Given this list of marker genes ADGRG3, ATP11A, IQGAP2, IGLV3-19, FCAR, LYN, SCAMP1, LY96, GHDC, BST1, PLCG2, C8A, YES1 (YES proto-oncogene 1, Src family tyrosine kinase), PGM2, CLEC4C, PRKCQ, OLR1, POLR3A, DEFB105A, WAS, PRKCSH, FYN, MUC17, TMT1A, PSMA2, MUC1 (NCBI Gene Id 4582), MUC4, TXK, PDZD11, ATP6V0D1, CCL22, CMTM6, GMFG, GLIPR1, UBA7, CSNK2B, RNF216, DEFB127, RAP1A, ATP6AP2 (ATPase H+ transporting accessory protein 2), HLA-C, IGKV2D-40, LGALS3, WIPF2, ABI2, USP14, DUSP6, TUBB4B, IGHV3-30, NFATC1, MYO1C (myosin IC), FCN3, UBB, TTR, MUC3A, BCL2, ATP6V0A1, ELMO2, CTSB, S100A9, NIT2, ATG7, AGPAT2, CTSG, NOD1, TRIM32, CFP, SNAP23, LY86, CD59, PLCG1, SFTPD, CD247, IMPDH2, ITPR2, CTNNB1, PRKDC, PGLYRP1, C9, POLR3B, RHOG, IGKV3D-20, LGMN, FGL2, PSMD11, IGKV1-39, S100A8, SLC2A5, DEFB130B, LRRC14, NFASC, STOM (stomatin), MAP3K8, NKIRAS1, HTN1, PADI2, RNASE6, PKP1, DBNL, HEBP2, XRCC5, CNN2, RNASET2, ADGRE5, YPEL5, ARG1, HVCN1, LEAP2, TICAM2, IGHV3-23, MS4A2, MME, AAMP, UBR4, AMPD3, CREB1, BCL2L1, GSDME, DNM3, CAPZA1, DDX3X, CALM1, LYZ, DGAT1, PTPN11, ANPEP, NOS1, PDAP1, C1QA, ABI1, CD58, SARM1, NBEAL2, JUP, HEXB, ARHGAP9, GLB1, RAB5B, IGHV1-2, CREBBP, PAK2, DEFB126, TMEM179B, PRDX6, ARPC3 (NCBI Gene Id 10094), DEFB1, CYLD, ARPC1A, SIKE1, DEFB132, PTPRN2, PSMD6, TLR4, RBSN, ELANE, STING1, DUSP3, PSMA6, MUC5B, IGKV1-12, NOD2, OSCAR, TLR3, CCT2, SLC27A2, RASGRP1, DTX4, CD300LB, CAT, TCIRG1, GSDMD, PSMC6, PYCARD, DEGS1, PI3, HK3, MALT1, CEP290, CTSS, HMOX2, HGSNAT, IFNA10, PGM1, C7, CD53, ENPP4, IGKV1D-33, ITPR3 (NCBI Gene Id 3710), ATAD3B, NDUFC2, CXCL1, TRPM2, C1S, GUSB, IGHE, GM2A, PSMB2, C3, MYO10, PRDX4, PTAFR, EPPIN, LPO, PA2G4, ALDH3B1, UBE2D1, MASP2, CKAP4, CFHR4, ADAM8, GZMM, ATP6V0E2, PLD3, RAB4B, QPCT, IGLV1-44, NLRX1, NFKBIA, SPTAN1, RETN, PPIA, NLRP1, LIMK1, ARL8A, DEFB4A, TNIP2, RAF1 (NCBI Gene Id 5894), DIAPH1, TMBIM1, ICAM3, TLR1, PRCP, IGLV2-14, CYB5R3, PDXK, CDK13, SUGT1, MMP25, NCKIPSD, SLC15A4, TLR7, NOS3, SERPINB3, CAPZA2, FUCA1, FTH1, S100A12 (NCBI Gene Id 6283), PSMA4, MYD88, LAMTOR1, MLEC, NHLRC3, IFNA2, EEF2, ANXA2, ACTB, DEFB125, POLR3GL, IGHG1, ATG12, ROCK1, PGRMC1, IGLV3-1, CASP4, FGG, IGHG2, PPP3R1, DEFB110, ALAD, A1BG, MAPK7, SFTPA1, FGA, SYNGR1, SIGLEC15, SRP14, CPN1, TREM2, TAB1, RAB3A, MNDA, PPBP, CD19, DSC1, GAB2, CPPED1, TLR8, PTX3, CASP8, CD180, MGST1, IGKV2-28 (immunoglobulin kappa variable 2-28), NCR2, PGLYRP4, IFNA6, BTRC, SIRPA, HSP90AA1, SEMG1, DNM1, MUC5AC, GLA, DEFB108B, SLC2A3, IGKV2D-28, DNAJC3, HP, CD68, CFI, IFI16, CTSA, ATP6V1B1, MMP9, POLR2F, MAP2K7, PNP (NCBI Gene Id 4860), TMEM63A, IGKV2-30, DEFB104B, ARHGAP45, MYO9B, KRAS, MYH9, CXCR1, CRACR2A, PTPN4, IRF3, IGKV1D-12, ECSIT, MAP3K7, DEFA3, CRCP, RHOF, DEFB130A, CTSH, AGA (aspartylglucosaminidase), ATP6V1C1, PSMD7, SRC, RNASE8, SKP1, MUC15, CANT1, N4BP1, DEFB109B, ACTR10, IGKV1-5, NRAS, ORM1, IGHV4-34, EPPIN-WFDC6, IGLV2-23, CHUK, RPS6KA3, MUC7, ITCH, CD177, CD93, MEF2A, FCGR3B, ARPC2, SLPI, FCER1A, DERA (NCBI Gene Id 51071), IGF2R, C2, EEA1, IGLV6-57, TXNIP, GALNS, IFIH1, MEF2C, S100A1, DNAJC5, ATOX1, CD46, MAPK12, PPP2R1A, CFHR5, LBP, CRISP3, SERPING1, PLD4, BIRC2, MGAM (maltase-glucoamylase), PRSS3, C5AR1, REG3A, PSMB4, RPS27A, LAMTOR2, MAPKAPK2, CPB2, UBA3, DEFB104A, DEFB121, COMMD3, CTSV, SAA1, IGKV5-2, B4GALT1, SDCBP, CASP10, FCN2, TLR6, ATP11B, TAX1BP1, MAP3K1, NF2, UNC93B1, PPP2R5D, ABL1, CCT8, ATP6V1E2, MS4A3, IFNA14, CHIT1, IGHV3-7, C6orf120, PELI1, RNASE3, MOSPD2, DEFB4B, P2RX7, IGKV2D-30, ATF2, PPP2CB, DEFB103B, CTSL, SOS1, ARSA, POLR3K, MAVS, HSPA1A, MUC21, VAPA, DEFB115, LILRB3, CXCR2, PSMD8, FPR2, POLR2L, CASP9, COLEC10 (collectin subfamily member 10), POLR3C, DOCK2, IFNB1 (NCBI Gene Id 3456), PIK3R2, IGLV3-25 (NCBI Gene Id 28793), DDX41, ASAH1, SHC1, PSMD13, ATP6V0D2, OTUD5, NFATC2, MAPK13, IGHV1-46, NME2, IDH1, DEFB131A, CUL1, TNFRSF1B, RAB7A, TRAF6, CDA, C4BPB, HSP90AB1, FABP5, IGKV3-20, NPC2, CLEC10A, IFNA21, ALDOC, IL1B, KRT1, SIGIRR, SIGLEC9, IRF7, SURF4, PTPRC, CST3, MAPK8, MIF, REG3G, HPSE, IGHV3-13, VNN1, CYFIP2, PLAUR, PIK3CB, ORMDL3, GSTP1, PLD1, ATP6V1E1, DEFB114, CD3G, UBE2D3, STK10, DEFA5, UNC13D, HSPA6, IGLV7-43, PSMA7, ACTG1, AGER, MAPK11, DEFB136, VRK3, GGH, TIRAP, RNASE2, DDOST, ITGB2 (NCBI Gene Id 3689), IGHV2-70, SLC44A2, RAB18, PGAM1, RIPK1, PSMC3, TRIM21, TNFAIP3, IFNA8, CD81, RAB10, IKBKG, ADAM10, POLR2E, MYO5A, TMEM30A, DSP, DEFB103A, SLC11A1, VCL, S100A7, VAV1, RIPK3, DYNC1H1, HLA-E, UBC, ADA2, CAND1, POLR2H, GRB2, PPP2CA, DEFB119, WIPF1 (NCBI Gene Id 7456), SIGLEC5, RPS6KA2, RELB, RAB37, SERPINB12, CPNE1, STBD1, CYFIP1, DYNC1LI1, PLPP5, CLEC6A, DEFB113, PTGES2, DYNLT1, KPNB1, TLR2, KIR2DS1, DOCK1, IRAK4, OPTN, PLA2G2A, APRT, SEM1, RAP2B, POLR1C, MBL2, FTL, CD14, S100A7A, GRAP2, ISG15, LAMP1, ARPC1B, IGKV1-17, ATP6V1G1, PKM, BPIFB6, SNAP29, TICAM1, DEFB112, TKFC, IGLV1-40, DEFB107A (NCBI Gene Id 245910), DEFA6, TAB2, CLEC4A, TRIM4, PRG2, VAMP8, DEFB129, WIPF3, ITGAM, PSMB7, TP53, TOM1, DNM2, MAP2K3 (NCBI Gene Id 92079), DEFB135, CR2, TLR5, ACLY, PGLYRP2, PLAU, CD44, MUCL1, C4A, HRNR, IGHV4-39, KIR2DS2, LRRC7, ITGAL, CRP, KLRC2, IGHV3-53 (immunoglobulin heavy variable 3-53), NCF1, NLRC3, DYNLL1, LRRFIP1, VAV2, IGHV3-48, NLRP3, MRE11, ART1, KLRD1, HBB, DUSP7, ATP6V0B, COTL1, DNAJC13, IKBKE, PRKACA, PTPRB, NLRC4, RAP2C, QSOX1, MAPK1, ATP6V1B2, MYH2, EP300, PSEN1, PSTPIP1, MASP1, ILF2, PSMD12, BPIFB1, TIFA, FCN1, C4BPA, PPP3CA, IFNA13, MAP2K6, IGHV3-33, AHSG, PLEKHO2, DOK3, C4B_2, RIGI, RAB44 (RAB44, member RAS oncogene family), IRF5, RAB14, PYGL, CD55, DHX9, GNS, XRCC6, MUC13, BPIFB2, DEFB107B, MAPK10, PPP2R1B, CFHR2, CYBA, RASGRP4 (NCBI Gene Id 115727), CHI3L1, RAC1, VAV3, ATP6V0E1, NLRC5, CAP1, CTSZ, F2, TAB3, HMGB1, ATP6V1A, CD4, FADD, MVP, IRAK3, TYROBP, ITK, LILRB2, CEACAM3, IFNA5, SERPINB10, EEF1A1, PSMB5, SVIP, CTSK, NCF4, C5AR2, PELI3, APEH, CAB39, MAN2B1, RAB27A, AHCYL1, CFHR1, TMC6, RAB3D, ITLN1, POLR3E, VPS35L, PSMC2, NLRP4, TBK1, RNF135, IGHV3-11, PSMD3, MAP2K4, STAT6, AZU1, C5 (NCBI Gene Id 727), CASP1, RASGRP2, IGLV1-51, C8B, CREG1, IFNA4, LCK (NCBI Gene Id 95387), IFNA7, MAPK14, SIGLEC14, IMPDH1, TRAF3, IST1, TREX1, BST2, RAB24, ATP6V1H, PSMC1, DEFB106A, ATP6V0C, HTN3, HSPA1B, PLPP4, ITGAV, IGKV1D-16, CTSC, POLR3F, NKIRAS2, PIGR, S100A11, GYG1, IGKV1D-39, ACAA1, PIK3C3, RAC2, BPIFB4, BPI, CYSTM1, PSMA1, ARSB, C1QC, CTSD, BCL10, C1R, MUC16, PSMB6, TRAF2, DCD, PRKACG, BTK, PCBP2, C1QB, KIR2DS4, RHOA, USP18, ACTR2, C4B, TXN, POLR2K (NCBI Gene Id 5440), ITGAX, EPX, CALML5, PECAM1, DEFB116, TOLLIP, IGKV3-11, ARPC5, DNASE1L1, RAP1B, BRK1 (NCBI Gene Id 55845), ATP8A1 (ATPase phospholipid transporting 8A1), POLR3G, PTK2, HUWE1, WASF3, SFTPA2, CPN2, POLR3H, NCSTN (nicastrin), ADRM1 (ADRM1 26S proteasome ubiquitin receptor), KLRK1, BAIAP2, PTPRJ, ATF1, PYGB, IGHV4-59, NCF2, PLA2G6, CFL1, CCR2 (C-C motif chemokine receptor 2), IGLV3-27, PSAP, ADGRE3, NFKBIB, ATP8B4, NOS2, TUBB, ATP6V1F, CD33, PSMA5, CRISPLD2, UBE2K, KIR2DS5, FOLR3, CGAS, TSPAN14, IFNA1, MAPK9, ATP6V1G2, CHGA, ELK1, PDPK1, HSPA8, DEFB124, PSMB1, DSG1, CCL17 (NCBI Gene Id 6361), UBA52, UBE2N, CPNE3, ICAM2, PPP3CB, PGLYRP3 (peptidoglycan recognition protein 3), ATP6V0A4, RNF125, ATP6V1C2, CFH, IGHV1-69, STK11IP, FCGR3A, ITPR1, SIRPB1, ACTR1B, LTF, KCNAB2, PRG3, PSMB3, TLR9, CR1, FLG2, TOMM70, PSMC5, POLR3D, DEFA1B, TBC1D10C, WASL, GAA, DEFB105B, FCER1G, DSN1, PAK3, WASF2, CD47, TRIM25, IGKV4-1, ERP44, CARD11, RPS6KA5, PIK3CA, MUC6, C8G, GPR84, ANO6, IGKV1-16, CAMP, MMP8, LAMP2, VTN, MAP2K1, IFNA16, FUCA2, ENSG00000284217 (NCBI Gene Id 128966554), LAT, CLEC12A, DEFB118, ATP7A, IRAK2, HCK, IGHV2-5 (NCBI Gene Id 28457), FRK, RAB31, BPIFA2, PFKL, CEACAM8, CYBB, BIRC3, APOB, CD300A, MEFV, FGR, ATG5, GPI, S100P, TXNDC5, PPIE, C3AR1, TANK (NCBI Gene Id 10010), MAP3K14, BPIFA1, ATP6V0A2, RELA, DEFB106B, MANBA, GCA, DEFA4, TEC, CRK, PAFAH1B2, VAT1 (NCBI Gene Id 10493), HERC5, ALDOA, B2M, TRIM56, CEACAM6, PELI2, PLAC8, IGKV1-33, FCGR2A, TARM1, CCR6, DEFB133 (defensin beta 133 (pseudogene)), TASL, LPCAT1, SNAP25, COMMD9, GNLY, CDC34, OSTF1, ACP3, CD36, CD63, ALOX5, SERPINB6, ALPK1, IGLC2, MUC12, WASF1, RPS6KA1, HRAS, CARD9, RAB6A, ELMO1, SLCO4C1, ACTR3, LAT2, IGLV3-21, LRG1, IGHG4, CSTB (NCBI Gene Id 1476), VCP, IRAG2, SERPINA1, SOCS1, GRN, ARMC8, HSP90B1, NCKAP1, NAPRT, CLEC5A, P2RX1, AOC1, SERPINA3, SYK, TLR10, IGLV1-47, AP1M1, OLFM4, NCK1, PSMD14, RIPK2, FBXW11, FCGR1A, PRSS2, TNFAIP6, ORM2, S100B, PRTN3, MAPK3, MCEMP1, FOS, IFNA17 (NCBI Gene Id 3451), CLEC7A, DEFB134, FRMPD3, PIK3R1, PSMC4, PRKACB, PIN1, PIK3R4, RAB9B, PSMD2, ABCA13, LAIR1, IKBIP, MUC20, LILRA3, APP, DHX36, POLR1D, MAPKAPK3, UBE2M, CEACAM1 (CEA cell adhesion molecule 1), FAF2, LCP2 (lymphocyte cytosolic protein 2), PSMD1, TCN1, UBE2D2, BRI3, PRKCD, DHX58, PLD2 (NCBI Gene Id 5338), CASP2, UBE2V1, IKBKB, MAGT1, FGB, TRAPPC1, FPR1, ATP6V1D, LTA4H, HLA-B, ATP6V1G3, COPB1, BIN2, NFAM1, PROS1, RAB5C, KCMF1, IQGAP1, CFB, LAMTOR3, CHRNB4, DEFA1 (defensin alpha 1), SELL, LCN2, DEFB123, RNASE7, IGLV2-8, IRAK1, GSN, CNPY3, GDI2 (NCBI Gene Id 2665), AP2A2 (adaptor related protein complex 2 subunit alpha 2), IGLC3, DEFB128, TIMP2, PTPN6, JUN, NEU1, CD209, AGL, PRKCE, CLU, ZBP1, CLEC4E, NFKB2, UBE2L6, CD300E, PANX1, C6, HMOX1, AIM2, NFATC3, NFKB1, MPO, CFHR3, PAK1, PSMA3, TREM1, IGLV2-11 (NCBI Gene Id 28816), COLEC11, SERPINB1, CAPN1, ARPC4 (NCBI Gene Id 10093), APAF1, NCKAP1L, IGKV3-15, CFD, CDC42, C1orf35, DUSP4, DPP7, GOLGA7, CLEC4D, KIR3DS1, here is a description of the gene set: Innate Immune System Human Gene Set: REACTOME_INNATE_IMMUNE_SYSTEM studied in species Homo sapiens